The following is a description of a gene set: Mouse Gene Set: GOBP_POSITIVE_REGULATION_OF_ACUTE_INFLAMMATORY_RESPONSE Any process that activates or increases the frequency, rate, or extent of an acute inflammatory response. species: Mus musculus, and this is the list of marker genes: Ffar3, Pik3cg, Alox5ap, H2-T23, Ccr7 (NCBI Gene Id 12775), Ccr5, Ighg2b, Fcer1a, Ffar2, Cnr1, C3, Tnfsf11, Il6, Adam8, Fcgr3, Il1b (interleukin 1 beta), Npy5r, Ccl5 (C-C motif chemokine ligand 5), Aoc3, Fcgr1, Ighg1, Tac1, Tnfrsf11a, Zp3, C2cd4b, Fcer1g, Park7, C2cd4a, Ptger3, Ptgs2, Btk, Tnf (NCBI Gene Id 21926)